Given this list of marker genes FLNA, HDAC6, CCAR2 (cell cycle and apoptosis regulator 2), HDAC3, HDAC9, SIRT5, BEX4, TPPP, SIRT1, BRMS1, FRY, SIRT7, NNMT, IFNG, MAPT, PRKAA2, HDAC1 (histone deacetylase 1), SIRT2, PRKAA1, HDAC4, SIRT4, SIRT6, EP300, HDAC7, SIRT3, here is a description of the gene set: Human Gene Set: GOBP_PROTEIN_DEACETYLATION The removal of an acetyl group from a protein amino acid. An acetyl group is CH3CO-, derived from acetic acid. species: Homo sapiens